Given this list of marker genes IFI44L, VWA7, GCHFR, ELF2P3, GRK6, TLK2, PCAT19, MIRLET7BHG, F12, here is a description of the gene set: species: Homo sapiens Genes containing one or more binding sites for (ZNF491) in their promoter regions (TSS -1000,+100 bp) as identified by GTRD version 20.06 ChIP-seq harmonization. Human Gene Set: ZNF491_TARGET_GENES from publication Yevshin I, Sharipov R, Kolmykov S, Kondrakhin Y, Kolpakov F (PMID 30445619)